Given this list of marker genes REEP1, GABRA3 (NCBI Gene Id 2556), ACTA1, YARS2, RYR1, CCDC78, AFG3L2, SYT2, ASCC1, SARS2, TRMT10C, POPDC3, KBTBD13, COL13A1, POMGNT1, GGPS1, AK9, POLG2, UQCRQ, MT-CO1, SLC25A4, FUS, COQ7, MT-ND4, BIN1, JAG1, DPAGT1, SLC5A6, SLC5A7, TNNT1, MGME1, STAC3, BVES, GDAP1, SLC12A6, MT-ATP8, LARGE1, MYO9A, KY, OPA1, TBCK, GNE, DGUOK, MFN2, MIPEP, CRPPA, PLIN4, MT-TS2, MT-TL2, KLHL41, DYSF, NEB, ISCU, SLC25A42, MT-ATP6, CACNA1S, LMOD3, MSTO1, ADGRG6, IFIH1, MYOT, LDB3, PLEC, RNASEH1, ALG2, POLRMT, FKBP14, HNRNPA2B1, HACD1, GOLGA2, COLQ, GARS1, AGTPBP1, GYG1, APP, OBSCN, SUCLG1, MT-TK, CASQ1, ABCA7, SLC25A1, CHRNB1, MYH2, PNPT1, FLNC, FKTN, AARS2, MEGF10, MT-TQ, PYROXD1, POMT1, SYNE1, ITGA7, SELENON, MT-ND6, LPIN1 (lipin 1), LMOD2, RILPL1, DPM3, FHL1, MT-TF, NEK9, HEXB, TNPO3, AGRN, MAP3K20, TWNK (NCBI Gene Id 60508), SDHA, MT-TL1, CAV3, FBXL4, MT-TC, KLHL40, TNXB, PNPLA2, SNAP25, CHRNA1, AHCY, MT-ND3, TMEM43, HNRNPDL, DMD, ALS2, TRIM32, MYL2, MTMR14, CHRND, YME1L1, DNAJB6, CNBP, VRK1, KIF5A, MTM1, TOR1AIP1, CAVIN1, MT-RNR1, ACTN2, SMN1 (NCBI Gene Id 91918), PFKM, UNC45B, HNRNPK, CTBP1, MT-TW, VAMP1, COL6A2, CHAT, NDUFB3, SNUPN, SORL1, MT-CO3, SPG11, TNNC2, TTN, NDUFS4, MT-TV, MT-ND1, SIGMAR1, VMA21, BCS1L, LIG3, POMK, COL6A3, SCO2, TYMP (thymidine phosphorylase), STIM1, TCAP, COX11, MUSK, NDUFA4, SYNE2, EMD, PABPN1, KCNE3, NUBPL, MT-TN, COL12A1, UBA1, CCDC174, CLCN6, LRP12, POLG, TOMM40, COQ5, MYH14, MT-CYB, TPM3 (NCBI Gene Id 91191), LAMP2, MT-TH, AIFM1, CAPN3, NEFL, NOTCH2NLC, SLC18A3, GFPT1, LMNA, LRP4, MYL1, EMILIN1, MATR3, GMPPB, VPS13A, PSEN2 (presenilin 2), GFER, MT-TP, TRIP4, POMT2, KCNA1, SPG7, MT-TE, TEFM, CHRNE, MT-CO2, MYO18B, HPDL, SMPX, HNRNPA1, RRM1, RRM2B, PSEN1, ALDOA, MPV17, LYRM4, SCN4A, MLIP, SGCG, ANO5, SLC25A12, MB, NARS2, GIPC1, SPTLC1, ADSS1, KCNJ18, SLC25A26, TRMU, LAMB2, SGCA, TIA1, SPTBN4, ALG14, GOSR2, MT-ND5, MT-ND2, MYPN, MICU1, FXR1, SQSTM1, TRPV4, SIL1 (SIL1 nucleotide exchange factor), CPT2, LRIF1, GLI3, DHX16, FKRP, SLC25A32, ORAI1, CARS2, JAG2, TPM2, COL6A1, CFL2, DES, DAG1, PUS1, EARS2, SPEG, PPARG (NCBI Gene Id 5468), ANXA11, COQ2 (coenzyme Q2, polyprenyltransferase), CHKB, TREM2, VCP, HMGCR, DYNC1H1, CHCHD10, DOK7, RYR3, TAMM41, TK2, TRAPPC11, LAMA2, MIEF2, PLOD1, MYH7, MT-TI, NEFH, MYF6, PHKA1, SGCB, DNM2, RAPSN, CRYAB, here is a description of the gene set: Any abnormality of the skeletal muscle cell. Muscle fibers are subdivided into two types. Type I fibers are fatigue-resistant and rich in oxidative enzymes (they stain light with the myosin ATPase reaction), and type II fibers are fast-contracting, fatigue-prone, and rich in glycolytic enzymes (these fibers stain darkly). Normal muscle tissue has a random distribution of type I and type II fibers. Abnormal muscle fiber morphology species: Homo sapiens Human Gene Set: HP_ABNORMAL_MUSCLE_FIBER_MORPHOLOGY